The following is a description of a gene set: Mouse Gene Set: GOBP_POSITIVE_REGULATION_OF_TRANSCRIPTION_OF_NUCLEOLAR_LARGE_RRNA_BY_RNA_POLYMERASE_I Any process that activates or increases the frequency, rate or extent of transcription of nuclear large rRNA mediated by RNA polymerase I. species: Mus musculus, and this is the list of marker genes: Mars1, Mtor (NCBI Gene Id 80612, mechanistic target of rapamycin kinase), Nol11, Ddx11, Smarca4, Ncl, Smarcb1, Pwp1, Pih1d1, Ippk